Given this list of marker genes ARF3, DGCR2, CLCA1, PPP4C, DHRS3 (dehydrogenase/reductase 3), PRRC2C, NAA30, ID1, NEDD4, ABLIM1, FSCN1, LPP, TTC9C, SEPTIN10, ZNF704, ARHGEF2, TXLNA, HMGCR, ALDH1A1, LRATD2, TIMP2, CRIM1, PLAGL2, KHDRBS3, GYPC, KLF3, PTGR1, AHNAK, SDF2L1, ZBTB14, ADAM17, HCFC1R1, MAGED1, PSMD2, KANSL1, ZNF664, ANKHD1, NUFIP2, GLMP, PSMB2, GOLIM4, BCL9, UXS1, WAC, CAT, NOLC1, BCKDHA, SNW1, MARCHF7, GSG1L, ID2, ABHD17C, CLIC4, NCOA6, RCOR1, PSAP, SF3B2 (NCBI Gene Id 170474), MYO1B, MANF, RHOB, PHKG2, CHD1 (chromodomain helicase DNA binding protein 1), PPHLN1, SOX9, TAF1, QRICH1, ENPEP, SERF2, PPP1R37 (NCBI Gene Id 56148), ERGIC1, WASF2, ARID4A, SERTAD3, ECD, ITGB5, PARVA, KBTBD2, VPS36, LRP1, PTPN11, ZNF462, GRIA4, RFX7, ATAD2B, EPCAM, NRIP1, OARD1, PTOV1, CHD9, PPP1CA, CUTA (cutA divalent cation tolerance homolog), NOC2L, GBF1, NUCKS1, AKR7A2, PEX5, ZC3H13, CTBP1, DAGLB, WWC1, CAMK2N1, COL23A1, GOLPH3, BSDC1, H2AC4, ZBTB11, PRKCSH, SHTN1, PFDN2, GOLGA4, SSH1, PHETA1, PLET1, DHX36, PDZD8, REST, GCC2, AGO1, RAD23A, GADD45G, BZW1, DCTN4, SIPA1L2, CAMK1D, TRIOBP, CLDND1, ZMYND8, GTF2H3, MYBBP1A, L3HYPDH (NCBI Gene Id 112849), CXXC1, CD2AP, PUM1, RNF122, TMED2, UBR2, ME2, TNKS1BP1, MYOCD, MLLT3, NUDT3, H1-4, NCOR1, SYMPK, CYP2F1, ZFHX3, DEK, HOXD13, DNAJC1, AKTIP, ZHX1, MYCL, PIKFYVE, HDAC4, CLPTM1, FKBP4, CASP7, CXADR, ADNP2, CNN2, MPRIP, SEPTIN9, FRAS1 (Fraser extracellular matrix complex subunit 1), DNLZ (NCBI Gene Id 731607), ZNF410, ALYREF (NCBI Gene Id 10189), TCF20, MED25, DNAJB11, PSMC4, LIMA1, CANX (NCBI Gene Id 821), PTPRJ, PSMD12, H2AJ, LDB2, AFTPH, CDC37L1, UPK2, LZTS2, HSD17B7, ZNF644, PPIL1, UPK3A, LLPH, PABPN1, H4C14, PCNX3, DYNLL2, SART1, SPRR1A (small proline rich protein 1A), CNPY2, NFIA, GIGYF2, PABPC4L, SINHCAF, SAMD5, TNRC6A, PTGFRN, NDUFA4, KDM6B, GATA2 (NCBI Gene Id 84724), GATA3, PDE3A, GRN, ELOVL5 (ELOVL fatty acid elongase 5), UHRF1, MBOAT2, DZIP1, TBC1D17, CSNK1A1, GPD2, H4C9, NECTIN1, EIF3J, DHX29, C1orf116, MYDGF, GIPC1, GON4L, CSPG5, SPPL3, SLC39A10, SENP3, AFF3, SMARCA2, MGAT1, CDK5RAP2 (CDK5 regulatory subunit associated protein 2), TAOK1, SPTBN1, RSRC1, H1-2, SNRPD3, SHKBP1, SNRPF, RFWD3, PKM, H4C16, TPM3, FURIN, ST13, SND1, ETS1, GPC1, PHF6, KLHDC10, TCF3 (transcription factor 3), SERTAD2, LEPROTL1, KRT19, IER3IP1, NOL8, SMOC2, SMG6, NEK7, HMG20B, AAMP, FGFR1OP2, INHBA, BAHCC1 (BAH domain and coiled-coil containing 1), CALD1, NFYA, LITAF, PTPRD, PHF13, UBE2I, CHPT1, RBM27, DENND2B, KDELR2, PALLD, HNRNPC, LY6H, DNMT3A, NOTCH1, TOB2, PPP4R3A, CDK2, CEP170B, LSP1, RND3, SKP1, UQCC2 (NCBI Gene Id 84300), ZNF274, KRAS, IRF2BP2 (interferon regulatory factor 2 binding protein 2), CSRP1, DYNC2I1, C3orf70, DUSP7, SPR, PLIN3, CLTC, H1-5, ORAI3, VPS54, NLGN3, CDC27, CALR (calreticulin), POLDIP3, WNK1, RAB12, DERL1, ANXA9, SNRNP70, BCL2L1, MICU2, SCAND1, DIS3, EPHA7 (EPH receptor A7), S1PR3 (sphingosine-1-phosphate receptor 3), SLC38A10, PDIA4, MIA2, CABLES2, SAP30, UBFD1, MORF4L1, BCL7A, ID3, PKP4, CLDN7, RWDD4, TASOR, ARHGAP29, CDK14, BCLAF1, BMP4, APH1A, C5orf24, MACO1, FLNC, DNMT1, RRP1, NR4A2, STK25, AUTS2, TET2, ITGB1, PHB1, BLTP2, BAZ2B, CCNI, TFDP1, NFIX, SLC8A1, ARPC4, PPP2R5E, NASP, CEMIP2, MAP7D1, CBX4, KDM3B, RC3H2, FRYL, BCL2L12, HNRNPU, NAV1, FOXN3, GSPT1, TBC1D16, TIAM1, PLCXD3, TMEM132A, IER5L, DDX6, ZNF880, HSP90B1, HNRNPA0, RNF111, KCNK1, GNAI2, ARHGAP10, TAX1BP1, L3MBTL3, SEPTIN7, AGO2, SMTNL2, METTL3, PHLDB2, EIF4A1, BRD4, PTMS, PTGES3, RANGAP1, POFUT1, SENP2, EIF4B, ELAVL1 (ELAV like RNA binding protein 1), CHD4, RPS19 (NCBI Gene Id 8378), MNT, KDM5D, SFPQ, HSPA8, TBC1D10A, BTG1, CD2BP2, OXCT1, APPBP2, ATP1B1, DPYSL2, SYT13, TIMM17B (NCBI Gene Id 10245), CNOT11, MGST3, RBFOX2, NREP, ILF3, TRIM8, PDZD2, ARHGDIA, RBMS3, H2AC18, ADAMDEC1, TP53, PTK7, NAT14, B4GALT2, KMT2C, TRIM17, DNAJC2, FAT4 (FAT atypical cadherin 4), DOLPP1, ARID5B, FAM171A2, GSR, ALDH3B2 (aldehyde dehydrogenase 3 family member B2), UBAP2L, CREBBP, BTBD2, ING4, THRAP3, HGS (hepatocyte growth factor-regulated tyrosine kinase substrate), LEF1, LACTB, TM9SF1, CIAO2A, PRR13, H4C1, PRRX1, SIN3B, YWHAE, HOXA13, DAZAP1, KRT8, SET, SP6, SKI, PFN1, STRN3, MDFI, EMC1, ADIPOR1, SRSF9, MOV10, ATP5ME, TJP2 (NCBI Gene Id 9414), TNRC6B, VAPA, APP, KIF2A, PCDH18, VANGL2 (NCBI Gene Id 57216), TLK1, WNT6, here is a description of the gene set: studied in species Mus musculus from publication Schaeffer EM, Marchionni L, Huang Z, Simons B, Blackman A, Yu W, Parmigiani G, Berman DM (PMID 18794802) Genes down-regulated in the urogenital sinus (UGS) of day E16 females exposed to the androgen dihydrotestosterone for 6 h. Human Gene Set: SCHAEFFER_PROSTATE_DEVELOPMENT_6HR_DN Cancer cells differentiate along specific lineages that largely determine their clinical and biologic behavior. Distinct cancer phenotypes from different cells and organs likely result from unique gene expression repertoires established in the embryo and maintained after malignant transformation. We used comprehensive gene expression analysis to examine this concept in the prostate, an organ with a tractable developmental program and a high propensity for cancer. We focused on gene expression in the murine prostate rudiment at three time points during the first 48 h of exposure to androgen, which initiates proliferation and invasion of prostate epithelial buds into surrounding urogenital sinus mesenchyme. Here, we show that androgen exposure regulates genes previously implicated in prostate carcinogenesis comprising pathways for the phosphatase and tensin homolog (PTEN), fibroblast growth factor (FGF)/mitogen-activated protein kinase (MAPK), and Wnt signaling along with cellular programs regulating such 'hallmarks' of cancer as angiogenesis, apoptosis, migration and proliferation. We found statistically significant evidence for novel androgen-induced gene regulation events that establish and/or maintain prostate cell fate. These include modulation of gene expression through microRNAs, expression of specific transcription factors, and regulation of their predicted targets. By querying public gene expression databases from other tissues, we found that rather than generally characterizing androgen exposure or epithelial budding, the early prostate development program more closely resembles the program for human prostate cancer. Most importantly, early androgen-regulated genes and functional themes associated with prostate development were highly enriched in contrasts between increasingly lethal forms of prostate cancer, confirming a 'reactivation' of embryonic pathways for proliferation and invasion in prostate cancer progression. Among the genes with the most significant links to the development and cancer, we highlight coordinate induction of the transcription factor Sox9 and suppression of the proapoptotic phospholipid-binding protein Annexin A1 that link early prostate development to early prostate carcinogenesis. These results credential early prostate development as a reliable and valid model system for the investigation of genes and pathways that drive prostate cancer.